The following is a description of a gene set: species: Mus musculus Mouse Gene Set: GOBP_SKELETAL_MUSCLE_THIN_FILAMENT_ASSEMBLY The aggregation, arrangement and bonding together of proteins to form the actin-based thin filaments of myofibrils in skeletal muscle., and this is the list of marker genes: Lmod3, Acta1, Tcap, Ttn, Prox1, Actc1